Given this list of marker genes Kitl, H2az1, Utp25, Upp1, Zranb3, Nolc1, Ccna2, Map2, Gpc6, Cdca4, Ercc6l, Nasp, Ncapg2 (NCBI Gene Id 76044), Cenpa, Birc5, Haus4, Kif22, Pbk, Ptges2, Wdr62, Exosc6, Cep55, Suv39h2, Gins2, Dctd, Arhgap19, Tmem109, Fign, Mcm2, Pafah1b3, Cdc7, Mdc1, Ctc1, Isoc1, Cenpt, 2700049A03Rik, Rrp12, Parpbp, Slc29a2, Nkd2, Nusap1, Myb, Tead1, Fn1, Rfc3, Nemp1, Eme1, Ska2, Taf5, Gemin6, Slc1a3, Cenpm, Golt1b, Mis18bp1, Ptov1, Ankle1, Bok, Arhgap11a, Dnmt1, Ppp2r5c, Rfc4, Nes, Slc9a5, Cdca5, Igf1r, Kif20b, Stag1, Vim, Gm42047, Tcf19, Aspm, Dock5, Stambpl1, Kif11, Ect2, Lancl2, Tedc2, Xrcc2, Impa2, ENSMUSG00000127189, Haus5, Rrm2, Eri2, Cenpp, Sgo1, Xpo1, Vrk1, Aunip, Kif20a, D17H6S56E-5, Knl1, Wdr90, Depdc1b, Mcm7, Ccnk, Fbxo5, Polr1h, Cdk2, Mms22l, Timeless, Fen1, Wdr76, Cip2a, Gnl1, Tpm1, Hirip3, Clic1, Psrc1, Nanos1, Mre11a, Abcb1b, Smc4, Tyms, Ccdc77, Ndc80 (NCBI Gene Id 67052), Ifrd2, Dkc1, Racgap1, Id1, Mef2c, Zfp101, Rangap1, Kntc1, Pole2, Spred2, Chaf1b, Dlgap5, Trps1, Mlec, Ankrd24, Lsm5, Ska3, Fam83d, E2f7, Tedc1, Csrp2, Thap12, Haus1, Pdzrn3, Rnf26, 4930579G24Rik, H1f10, Mki67, Vars1, Cpne8, Aldh16a1, S100a4, Snx25, Tdp2, Odc1 (ornithine decarboxylase, structural 1), Lin9, Nfib, Ncaph2, Pold2, Ddias, Psmc3ip, Kif4, Msh6, H2ax, Ccdc61, Tipin, Skp2, Fignl1, Aen, Rfc2, Gemin5, Pole, Firrm, Plk1, Stil, 4933404O12Rik, Fgfr3, Bub1b, Snx7, Podxl, Gm4870, Hdac4, Haus8, Ctdspl2, Spc25, Gfod2, Cdca7, Akr1e1, Pa2g4, Eral1, Pola2, Top2a, Prc1, Nup85, Ckap5, Cd38, Gap43, Pold3, Umps, Tspan7, Ccne2 (NCBI Gene Id 12448), Orc1 (origin recognition complex, subunit 1), Ptn, Nle1, Chek1, Tesc, Sgo2a, Lpcat4, Mad2l1, Etaa1, Ckap2l, Cenpl, Nup107, Noc2l, Cenpe, Map3k20, Cit, Anxa2, Ddx20, Mis18a, Serpine2, Zc3h8, Brip1os, Ppif, H2ac24, Aida, Dna2, Rps6ka6, Siva1, Slc7a2, Srgap2, Lsm2, 2610318N02Rik (RIKEN cDNA 2610318N02 gene), Sertad4, Nup54, Cenpq, Tbc1d31, Ncapd2, Wee1, Pawr (NCBI Gene Id 76427), Lmnb2, Gjc3, Phf1, Hells, Sppl2a, Pold1 (polymerase (DNA directed), delta 1, catalytic subunit), Nptxr, Cdt1, Lmnb1, Haus6, Mtfr2 (NCBI Gene Id 71804), Rbm10, Ccnb2, Ncl, Cdca3, Lig1, Traip, Prim2, Poc1b, Ankrd6, Cenps, Cep152, AI506816, Ezh2, Tmem47, Kif18b, Rif1, Cbr3, Pabpc1, Cdkn3, Tk1, Fancd2, Cenpw, Prim1, E2f1, Esco2, Rad54l, Zwilch, Cep192, Hira, Xrcc1, Adgrl2, Pdss1, Cyp26b1, Larp7, Gm4739 (predicted gene 4739), Isy1, Fbxl18, Clspn, Selenoh, Ccne1, Ifit2, Mad1l1, Vcan (versican), Dscc1, Nup37, Hmgn2, Hrob, Anp32e, Ttll4 (NCBI Gene Id 98360), Dynll1, D430020J02Rik, Pdlim1, Cenpu, Fam234a, Nt5dc2, Limch1, Rad50, Hmgb3 (high mobility group box 3), Slf1, 2610005L07Rik, Tamm41, Dusp12, Cks2, 2900022M07Rik, Trmt61a, Rrm1, Spc24, Pidd1, Sparc, Rock1, Exosc8, Lasp1 (LIM and SH3 protein 1), Iffo2, Cdh6, Cks1b, Anks1, Foxm1, Cdkn2a, Peg3, Ckap2, Gmnn, Rc3h2, Hyls1 (NCBI Gene Id 76832), Mrnip, Rrp1b, Rsrc2, Hoxa4, Rcc1, Tacc3 (transforming, acidic coiled-coil containing protein 3), Creb5, Nsl1, Neurl1b, Mcm4, Tpx2, Polr2a, Pttg1, Kpna2, Depdc1a, Rpa2, Usp1, Gemin2, Arhgef39, Espl1, Mtln, Emp1, Plagl1, Mns1, Jpt1, Fam110a, Plekho1, Rdm1, Ldlr, Sfxn2, Uhrf1, Aaas, Hmgb2, Ier5l, Atad5 (NCBI Gene Id 319895), Lyar, Dbf4, Erbb3, Casp7, Lsm4, Fanci, Hmmr, Rpa1, Pask, Hmgn5, Mir1949, Akap12, Kif2c, Zfp41, 2700099C18Rik, Rbbp4, Ldhb, Mcm6, Mcmbp, Sall3, Stk17b, Dtl, Ncapg, Exo1, Rflnb, Pclaf, Jak1, Phf19, Rfc5, Dctpp1, Mybl1, Knstrn, Ncaph, Mcm8, Asph, Cenpn, Cep131, Snx22, Spdl1, Nop58, Jade1, Net1, Pimreg, Adam23, Ddah1, Anxa1, Cdc25b, Pmf1, Rbl1, Bub1, Kif18a, Suv39h1, Gas2l3, Ttk, E2f2, Fmc1, Rbmx2, Ptpn6, Mxd3, Cenpi, Vopp1, Wdhd1, Ccdc18, Cmc2, Gtse1, Fam72a, Pola1, Sart3, Itgb3, Iqgap3 (NCBI Gene Id 99678), Melk, Pif1, Ttf2, Nek2, Prr11, Mcm5, Terf1, Peg12, Dlgap1, Cacng4 (NCBI Gene Id 54377), Cdc20, Cdc45, Pxylp1, Cenpf, Troap, Bend3, Cdca8, Kif23, Palld, Ddx11, Cenpk, Taf4, Ppargc1b, Mybl2, Pkmyt1, Rad51, Angptl2, Stub1 (NCBI Gene Id 80391), Nuf2, Mreg, Cdca7l, Atad2, Fanca, Cdkn2c, Ticrr, Ccnb1, Smpdl3b, Mcm10, Gins1, Hat1, Ndc1, Ak4, 8030445P17Rik, Fam111a, Ptgr1, Uchl5, Enkd1, Haus3, Dhfr, Slc25a10, Tonsl, Dnaaf2, Palb2, Ccnd3, Cdc25c, Zfp704, Sephs1, Taf15, Lin54, Chek2, Ccnf, Smc2, Gpatch4, Limk1, Tal1 (T cell acute lymphocytic leukemia 1), Tgif2, Zbtb12, Hjurp, Haspin, Kifc5b, Thyn1, Incenp, Aurka, 2810408I11Rik, Trip13, Ska1, Cdca2, Tmem107, Srm, Lgr5, Lockd, Nup133, L3mbtl2, Rad51ap1, Alad, Nup210, AU020206, Lrr1, Nsd2, Asf1b, Arhgap18, 9430015G10Rik, Spag5, Lpin2, Mcrip2, Blvrb, Adgrg6, Stmn1, Cep89, Casp3, Nucks1, Oip5, Dut, Spats2l, Bora, Dnajc9, Gpr161, Fbn2, Nup43, Chsy1, Samhd1, Tex30, Aurkb, Brca2, Osbpl3, Blm, Trim59, Shmt1, Atoh8, Sass6, Mtss1, Shcbp1, Cenph, Chtf18, Myg1, Cdk1, Tmem97, Batf3, Rgcc, Tbl2, Recql4, Shq1, Cand2, Hspb6, Gpr19, Tcof1, 4833412K13Rik, Smo, Slfn9, Malat1, Fmnl3, Ccdc34, 3110082I17Rik (RIKEN cDNA 3110082I17 gene), Zfp367, Kmt5a, Slbp, Ube2c, Cep70, Mdp1, Rad18, Ube2t (ubiquitin-conjugating enzyme E2T), Pvt1, Cdc6, Pbxip1, Plk4, Ung, Fstl1, Nmral1, Grwd1, Pms2, Mcm3, here is a description of the gene set: Inadequate remyelination of brain white matter lesions has been associated with a failure of oligodendrocyte precursors to differentiate into mature, myelin-producing cells. In order to better understand which genes play a critical role in oligodendrocyte differentiation, we performed time-dependent, genome-wide gene expression studies of mouse Oli-neu cells as they differentiate into process-forming and myelin basic protein-producing cells, following treatment with three different agents. Our data indicate that different inducers activate distinct pathways that ultimately converge into the completely differentiated state, where regulated gene sets overlap maximally. In order to also gain insight into the functional role of genes that are regulated in this process, we silenced 88 of these genes using small interfering RNA and identified multiple repressors of spontaneous differentiation of Oli-neu, most of which were confirmed in rat primary oligodendrocyte precursors cells. Among these repressors were CNP, a well-known myelin constituent, and three phosphatases, each known to negatively control mitogen-activated protein kinase cascades. We show that a novel inhibitor for one of the identified genes, dual-specificity phosphatase DUSP10/MKP5, was also capable of inducing oligodendrocyte differentiation in primary oligodendrocyte precursors. Oligodendrocytic differentiation feedback loops may therefore yield pharmacological targets to treat disease related to dysfunctional myelin deposition. Mouse Gene Set: GOBERT_OLIGODENDROCYTE_DIFFERENTIATION_UP from publication Gobert RP, Joubert L, Curchod ML, Salvat C, Foucault I, Jorand-Lebrun C, Lamarine M, Peixoto H, Vignaud C, Frémaux C, Jomotte T, Françon B, Alliod C, Bernasconi L, Abderrahim H, Perrin D, Bombrun A, Zanoguera F, Rommel C, Hooft van Huijsduijnen R (PMID 19139271) studied in species Mus musculus Genes up-regulated during later stage of differentiation of Oli-Neu cells (oligodendroglial precursor) in response to PD174265.